The following is a description of a gene set: studied in species Homo sapiens Human Gene Set: WP_MALE_INFERTILITY Male infertility, and this is the list of marker genes: XRCC2, THBS1, CTCFL, CDC42BPA, MTHFR, ABLIM1, PRDM9, XRCC3, XRCC4, LRWD1, CRISP2, SIRPG, MAS1L, CHD2, PUM2, CDK9, MSH4, PON1, XRCC5, UBR2, USP8, AR, CREBBP, SLC16A7, LTF, HMGA1, PIWIL1, MMP9, HLA-DRA, POLB, SOD2, POLG, BCL2, PEX10, ABCB1, ATM, PARP1, SPO11, PRM3, AHR, FAS, FASLG, VCX, IHO1, TNF, PIWIL2, PACRG, SOX5, CCNT2, TMEM132E, BRCA2, STRA8, GNAO1, DAZ2 (deleted in azoospermia 2), NFE2L2, MSMB, CYP1A1, ERCC2, MMP2, DAZ4, LIG4, MTRR, DND1, TEX15, SEMG1, REC8, NQO1, SLC46A1, CLU, MSH5, SHMT1, NANOS1, H3-4, TAS2R38, CXXC1, ESR1, CLOCK, TCN2, SEPTIN12, CYP26B1, EPSTI1, DDX4, SRD5A2, H4C1 (H4 clustered histone 1), HORMAD1, TRIP13, PIWIL3, DAZL, TSSK4, CCNT1, TSSK6, PSAT1, CCNA1, UBE2B, EP300, PON2, MLH3, CCNK, PRMT6, MOV10L1, RAG1, KDM3A, H2BW1, MTHFD1, DAZ3, DDX20, PMS2, KLK2, SOD3, EPPIN, MTR, NOS1, DAZ1, ETV5, INSR, BHMT, MLH1, OR2W3, PRM2, SIRPA, BRDT, RGS9, ESR2, RFC1, PRM1, APOB, NOS2, YBX2, HORMAD2, UBD, XPC, NOS3, GPX1, MDM2, BMAL1, AHRR, AGO2, CYP17A1, USP26, ERCC1, CAT, PEMT, SPATA17, PIWIL4, FOLH1